The following is a description of a gene set: Human Gene Set: HP_BRACHYCEPHALY species: Homo sapiens An abnormality of skull shape characterized by a decreased anterior-posterior diameter. That is, a cephalic index greater than 81%. Alternatively, an apparently shortened anteroposterior dimension (length) of the head compared to width. Brachycephaly, and this is the list of marker genes: SRD5A3, ALX1, ZIC1, TCF12, H4C5, HUWE1, FUCA1 (alpha-L-fucosidase 1), NEK1, POLR2A, HDAC8, STXBP1, SPEN, PQBP1, CRELD1, KIDINS220, CAMK2A, PTPN11, B3GLCT, ZMYND11, FHL1, PIGT, KMT2C, SMG9, POLR1D, PTH1R, SETBP1, NBAS, MED12, RAB3GAP2, HSPA9, PGAP2, GRIA3, ATIC, FGFR2, HNRNPC, UBE3B, UPF3B, DEAF1, UBE4B, CD81, RNU4-2, UNC80, ANKRD17, ALDH18A1, IRX5, PRKD1, TBC1D20, TRIP12, CA2 (carbonic anhydrase 2), FLII, FREM1, CDH11 (cadherin 11), FBXO11, UBE3A, AGA, KCNAB2, ZDHHC9 (zinc finger DHHC-type palmitoyltransferase 9, NCBI Gene Id 93950), POR (cytochrome p450 oxidoreductase), TBCK, COL11A1, RMRP, ATP7A, PHF21A, HDAC4, BRAF, ADAMTSL1, ALX4, CTU2, RAB23, IQSEC2, ADSL, RBM8A (RNA binding motif protein 8A), LRP5, RAC3, IPO8, TNFRSF13C, MMP23B, TECPR2, CASZ1, LUZP1, GET4, CLCN3, CDK10, GNB2, CHD6, PEX1, SMS, NFKB2, TTC8, SMC3, FAM20C, SYT1, XRCC4 (NCBI Gene Id 7518), TTC5, SUFU, MSX2 (NCBI Gene Id 8053), NALCN, TAPT1, ADAMTS10, MBD5, RFX7, SMC1A, AMER1, WASHC5, ESCO2, DDX3X, MAF, MAN2B1, HNRNPR, PRDM16, CNOT3, MMP14, PTCH2, TAF8, RAB18, CR2, EFNB1, RAB3GAP1, TBX2, DPYSL5, ERF, GOLGA2 (NCBI Gene Id 2801), DSE, CCDC47, TBC1D24, WDR26, ZBTB20, ANKRD11, MGAT2, MMP2, SPOP, IL11RA (NCBI Gene Id 3590), RAF1, CD19, ADARB1, BMP4 (bone morphogenetic protein 4), GJA8, INTU, TET3, PIGO, SATB2, SH3PXD2B, FKBP10, FBN2, CTCF, FGFR1, BRD4, PIGL, GABRD, POLR3A, SATB1, HSPG2, PCGF2 (NCBI Gene Id 7703), POLR1C (NCBI Gene Id 9533), ATP2B1, USP9X, NGLY1, PTCH1, MN1, RAD21, TBL1XR1, ICOS, NIPBL, SNRPN, MESD, TUBB, B3GAT3, RNF216, FKTN, TDP2, PDPN, DRG1, RUNX2 (RUNX family transcription factor 2), DPH1, MTX2, PIGW, RALGAPA1 (Ral GTPase activating protein catalytic subunit alpha 1), TAF6, PAICS, GJA1, AHDC1, EXT2 (exostosin glycosyltransferase 2), BUB1B, TCF20, GJA5, PIGV, ACOX1, POLR1B, PIGA, RERE, EBF3, USP7, TMCO1 (NCBI Gene Id 54499), FGFR3, FBN1, COL2A1, IRF2BP2, TCOF1, WAC, TRAPPC9, LRPPRC, MECP2 (methyl-CpG binding protein 2), ADNP, GALNT2, ATP6V1B2, TNFRSF13B, CHST14, SKI, LMX1B, SLC12A6, ERI1, PDE4D, POGZ, PRMT7, PRKAR1A, STAC3, ZC4H2, TWIST1, MS4A1, MEGF8, MED13L, SPECC1L, CYP26B1, PNPLA6, TRPV6, FOXF1, RECQL4, CHST3, SETD5, ZSWIM6, PIGY, SP7, PRKCZ, GBA1, LIG4, AUTS2, RNU12, PCLO, NANS, HCFC1, TNFSF12, NFKB1, PTRH2, TGFB3, ALG9 (NCBI Gene Id 79796), NOVA2, OTUD6B, DPH2, KDM1A, EHMT1 (NCBI Gene Id 79813), RAI1, PGAP3, BAP1 (BRCA1 associated deubiquitinase 1), H3-3B, SLC25A24, ARID1B